Given this list of marker genes GLI1, SOSTDC1, LTB, PTCH1, EDARADD, EDAR, EDA, WNT3, RELB, SHH, BMP1, DKK1, DKK4, here is a description of the gene set: species: Homo sapiens Human Gene Set: WP_EDA_SIGNALING_IN_HAIR_FOLLICLE_DEVELOPMENT EDA signaling in hair follicle development